Given this list of marker genes CAPN5, RPL19 (NCBI Gene Id 6143), SDC4, TRIB1, SCD, SERBP1, SLC25A15, OAT, ATF5, VPS37B, APOA4, GLUD1, PCOLCE, DECR2, SLC7A5 (NCBI Gene Id 8140), CAMK1, SLC50A1, RAB5A, DGAT2, LTBR, ANGPTL3, PSMB7, GNPTG, PCBP2, MYL6B, MT1B, LINC01554, MIEF1, CEMIP2, PYROXD2, FOXO4, LPIN2, AK3, SEC11A, EIF2AK1, PAFAH2, TM7SF2, EIF4A1, LRP5, COX5B, FASN, PRADC1, BCL2L13, CHCHD10, TPRG1L, UBAC1, HAGH, TTC39C, MOCOS, SAA4, ADH4, XPNPEP2, CDK2AP2, TMEM160, RMC1, PAM16, SHMT1, OAF, VPS28, INHBE, TBC1D16, CACNA1H, REEP6, SLC16A11, DNMT3L, CSK, SSU72, ADI1, AKR7A3, MAPKAPK3, AGPAT2, BPHL, FOXD4L4, RIC8A, NAA38, SDHB, LASP1, F8A1, HMGCS1, SMG5 (NCBI Gene Id 23381), FST, HADH, ABHD6, MAOA, TRIM8, HPR, FKBP4, DYSF, EVL, TRAPPC6A, PTMS, TEF, NUDT14, GSTA2, MICU1, TNIP2, STARD10, RETSAT, THOP1, PPP1R15A, ARHGAP10, PSMF1, GSTA1, NOCT, IDNK, ACTG1, CAPN6, EEF2K, RAB1A, PLAAT3, MGRN1, UROD, HAAO, CALML3, SH2B3, APH1A, FUOM (NCBI Gene Id 282969), VPS26B (VPS26 retromer complex component B), ATP1B1, CENPX, SLC35B1, PLEK2, CLDN2, DGAT1, OTC, OAZ1 (NCBI Gene Id 4946), NINJ1, QARS1, TAF15, HSD3B7 (NCBI Gene Id 80270), DESI1, CLPP, CYGB, ICAM3 (NCBI Gene Id 3385), AAMDC, ARMC6, DIAPH1, GNMT, MAGOH, DMAC2 (NCBI Gene Id 55101), GBP7, POLE3 (DNA polymerase epsilon 3, accessory subunit), ABCC2, NSDHL, ARNT, DYNLL2, CTSB, SNRPF, MRPS26, RAB5B, UBAP1, KHDRBS3, MXD4, DNAJB11, AHCY, TFF3, TECR, CERS6, UBE2J1, KPNA1, IGFBP4, CLDN3, MRPL22, SOD1, ALPL (alkaline phosphatase, biomineralization associated), RAB3GAP2 (NCBI Gene Id 26114), SPTAN1, BET1L, SAMD4A, OSBP, FITM1, TNFRSF1A, RNPEP, MEPCE, FEM1A (fem-1 homolog A), NUP62, ZNF689, AGT, GTF3A, ZNF672, SLC8B1, SRF, KCTD5, PBX3, DBH, ATP5PO, NUDT2, RND1, TMPRSS6 (NCBI Gene Id 164656), SH3BGRL2, FN3KRP, SLC19A3, POLR2F, POGK, AARS1, NUCB1, ENTR1, RXRA, STK35, NCOA4, WBP2, ENDOG, CCL16, SRPRB (SRP receptor subunit beta), KANK4, MRPL24, NFYC, ANXA10, AGMAT, MANF, F10, ACAT2, CD99L2 (NCBI Gene Id 83692), HMGCR, TUBB4B, TSHZ2, MRPS11, GOT2, ERLIN1, MRPL53, COQ10B, ABHD14B, MAT1A, CBS, SPTSSA, DHRS7, HPD, NR1H2, CYB5B, ACADSB, MLLT3, NPRL2, PCOLCE2, MYOM2, GPD1, SNRNP25, HSD17B14 (hydroxysteroid 17-beta dehydrogenase 14), EMP1, EEF2, UPB1, LDLR, SAP18, TMEM82, UCK1, ALG9, TP53INP2 (tumor protein p53 inducible nuclear protein 2), NUDT5, LONP1, MAPRE2, EFHD2, CBX7, PGRMC2, CPSF1, PDXK, PPM1F, H4C3, MRPS18A, ZDHHC5, NSFL1C, CMAS, SLC25A22, MACROD1, MYOM1, MAMDC4, TMEM97, FGGY, CDK9, SRPRA, STK11, RDH16, GPR88, IRF8, IGFALS, CYB561A3, PRDX5, SND1, MRPS31, CADM1, RPL36AL, PSMA3, CYP39A1 (cytochrome P450 family 39 subfamily A member 1), MVK, NDUFB8, NFKB1, CDA, ZNF281, HEPACAM, DDX18, SFXN1, EIPR1, ZFPM1, ZNF511, ROMO1, RPL12, CFHR3, RDH5, SERTAD1, DNAJA1, CENPV, ABHD10, ADH6, CNDP2, ZNHIT1, HPS6, ZBED1, ZNF330, PRG4, ATP6V0E2, PNP, ZFAND2A, CLPTM1, GPT2 (NCBI Gene Id 84706, glutamic--pyruvic transaminase 2), PHGDH, TST, CNOT2, HSPA5, RPS25, EML4, PGM2, BCO2, VAV2, DEFB1, TGDS, UBALD1, H3-3B, FGFRL1, MEA1, BOK, NNMT, GSE1, MPND, TBC1D14, ZCCHC14, CENPBD1P, NDFIP2, SLC20A2, ZNF180, SLC25A1, FAM20B, SHMT2, SREBF2, IMP4, ALDH7A1, PSMB4, TRRAP, NUDT3, TBL1X, NDEL1, DHRS1, FMO3, NMT1, SH3BP4, GALM, MYDGF, here is a description of the gene set: Human Gene Set: ACEVEDO_NORMAL_TISSUE_ADJACENT_TO_LIVER_TUMOR_DN species: Homo sapiens Genes down-regulated in normal tissue adjacent to liver tumor, compared to the normal liver samples. There is widespread interest in efficient characterization of differences between tumor and normal samples. Here, we show an effective methodology for genome-scale characterization of tumors. Using matched normal and tumor samples from liver cancer patients, as well as non-cancer-related normal liver tissue, we first determined changes in gene expression as monitored on RNA expression arrays. We identified several hundred mRNAs that were consistently changed in the tumor samples. To characterize the mechanisms responsible for creation of the tumor-specific transcriptome, we performed chromatin immunoprecipitation on microarray experiments to assay binding of RNA polymerase II, H3me3K27, and H3me3K9 and DNA methylation in 25,000 promoter regions. These experiments identified changes in active and silenced regions of the genome in the tumor cells. Finally, we used a virtual comparative genomic hybridization method to identify copy number alterations in the tumor samples. Through comparison of RNA polymerase II binding, chromatin structure, DNA methylation, and copy number changes, we suggest that the major contributor to creation of the liver tumor transcriptome was changes in gene copy number. from publication Acevedo LG, Bieda M, Green R, Farnham PJ (PMID 18413731)